The following is a description of a gene set: Genes down-regulated in CD8A dendritic cells: wildtype versus IFNAR1 knockout. Murine Cytomegalovirus (MCMV) infection leads to early activation of various immune cells, including B and T lymphocytes, before the actual initiation of antigen-specific adaptive immunity. This activation is partly driven by innate cytokines, including type I interferon (IFN), which are induced early after infection. The objective of this study was to address the role of type I IFN in shaping early/innate B and T cell responses to a primary acute viral infection. In order to decipher the specific impact of IFN-I on cell subsets, we performed a genome-wide expression analysis on WT splenic B and CD8 T lymphocytes isolated from C57BL/6 mixed bone marrow chimera mice. This study complements series GSE39555, which focused on early responses of NK cells and of the two subsets of conventional dendritic cells. Human Gene Set: GSE45365_WT_VS_IFNAR_KO_CD8A_DC_DN species: Homo sapiens, and this is the list of marker genes: TLK2, SPEF1, MAD2L1BP, FBLN2, ADGRD2 (NCBI Gene Id 347088), PCNX1, PTPN1 (protein tyrosine phosphatase non-receptor type 1), ADA, MFSD12, UFD1, ARID5A, UBE2L6, LPCAT1, BRAP, TALDO1, PEX26, BMP2, NINJ1 (ninjurin 1), PLCH2, PRKAG2 (protein kinase AMP-activated non-catalytic subunit gamma 2), ZC3HAV1, ARSD, UBE2Z, RASSF4, HIVEP2, ABL2, PARP12, DCTN4, TAP1, STX4 (syntaxin 4), PSEN1 (NCBI Gene Id 5663), DKKL1, SMOX, SNAI1, PSME2, RNF19A, CASP5, TP53AIP1, IRF7, EREG, SSTR2, RAPGEF2, RAB29, DDX39A, CAVIN2, SCNN1A, TRPV6, CTSV, LILRB1, BZW1, ARHGEF2, TRADD, PFKFB3, CCNA1, SRGAP2, ARAP2, NBR2, SAA3P, ADGRE2, ECE1, MRPL28, TNIP1, PLXNC1, DENND5A, PHF11, REL, TLR2, TDP2, PELI1, PDE4B, DDX56, BST2, SLC39A8, KMO, FPR2, UBXN4, GCKR, SFRP5, LRRFIP2, H2BC8, CASP3, F3, LSR, AKIRIN1, SIX5, CEBPE, EBI3, EHD1, PARP11, MXD1, ELL2, KBTBD2, CDKN2C, DENND2D, TIGAR (TP53 induced glycolysis regulatory phosphatase), BID, ST8SIA4, CSF3, LITAF, CDC37, GRB2, EIF1, OTUD4, GLRX, SOCS2, JOSD1, PPP1R15A, GBP2, STAT3, CXCL3, HAPLN2, TNFAIP3, ARFGAP1, LANCL2, PRKCG, ITPKC, TNFRSF1B, ROBO4, GRPEL1, ATAD3A, APOL2, IL4R, LGALS3BP, PLAGL2, CDC42EP2, SLC11A2, PRPF3, HERC6, LUC7L, CSNK1G1, NMI, IL15RA, PAF1, NBN, TP53BP2, STAT5A, C5orf15, PTGIR, IFITM1, SRP54, FUT5, GTF2B, NAPA, SLC7A11, CD80, APOA1, SAR1A, ITGA9, WAPL, LRP12, PSMD11, VEZF1, TJP1, AKAP4, GTF2F1, MFHAS1, CELA2A, SNIP1, MARK3, SPRED2, TRIM21, RIN2, CXCL2, DHX58, KLHL23, TICAM1, NUP58, RAB8B, NECTIN2, SLC2A6 (NCBI Gene Id 55587), SNRPB, SLC1A3, E2F8, SPHK1, SLC25A28, APOL1, MSC, YIPF6, MAP2K3, IFI44, H3-3B, SLC43A3, APOL6, IFIH1 (NCBI Gene Id 64135), NFKBIA, SPSB1, PTGER4, COL16A1, WARS1 (NCBI Gene Id 7453), TRIP12, RBM4, POMP, TNFAIP2, SDC4, ELF4, PDGFB, MFN1, CCDC40 (coiled-coil domain 40 molecular ruler complex subunit), PSMC1